The following is a description of a gene set: Human Gene Set: ILK_TARGET_GENES from publication Yevshin I, Sharipov R, Kolmykov S, Kondrakhin Y, Kolpakov F (PMID 30445619) Genes containing one or more binding sites for (ILK) in their promoter regions (TSS -1000,+100 bp) as identified by GTRD version 20.06 ChIP-seq harmonization. studied in species Homo sapiens, and this is the list of marker genes: LINC01732, STRIP1, SNHG20, IKBKB-DT, ZSCAN31, TULP2, ZFYVE1, KCNAB1, CARD8-AS1 (CARD8 antisense RNA 1), ENSG00000206898, LINC02252, NDUFAB1, SEC24C, LSM10, RNU2-2P, SEC14L1, PPP4R1L, C12orf76, LINC02842, LINC01719, SAMD9L (NCBI Gene Id 4827, sterile alpha motif domain containing 9 like), TRMT12, OPLAH, ATF7IP2, WDR74 (NCBI Gene Id 54663), MIR4766